Given this list of marker genes ATG9A, NINJ1, MUTYH, BIRC3, CFLAR, MIR103A1, MAP3K5, PELI1, ZBP1, RBCK1, MLKL, SPATA2, TNF, MIR107, PRKN, OGT, MIR92A1, MIR214, ATG9B, RIPK3, TSPO, PGAM5, TRPM7, IPMK, CYLD, SLC25A4, MIR221, PYGL, MIR485, BAX, TRAF2, AIFM1, ADPRS, CAV1, PPIF, PARP1, CASP8, FZD9, MIR22, TLR3, TP53, BOK, RNF31, NUPR1, ASAH1, FADD, NOL3, CASP6, FASLG, FAS, ALKBH7, IRF3, RIPK1, MIR101-1, ITCH (NCBI Gene Id 83737), NLRP6, BIRC2, YBX3, ITPK1, MIR223, ARHGEF2, here is a description of the gene set: A necrotic cell death process that results from the activation of endogenous cellular processes, such as signaling involving death domain receptors or Toll-like receptors. studied in species Homo sapiens Human Gene Set: GOBP_PROGRAMMED_NECROTIC_CELL_DEATH